Given this list of marker genes ADCY3, RCOR1, SH2D1A, IFRD1, ZFR, SP2, RGS16 (regulator of G protein signaling 16), TRIP10, ID3, SDCBP, ZNF330, SLC16A6, SRSF10, MDFIC, NR5A2, ADGRB2, PRL, ITPKB, FOXJ3 (forkhead box J3), RBBP5, PDCL, RNF103, MAST3, OGDH, SAMM50, PPIF, MBOAT7 (NCBI Gene Id 79143), LSM12, BRD2, SULT1C2, HTR7P1, DENND4B, PUM3, PTPRCAP, PRPF4, KHSRP, CD27, CD6, CD40 (CD40 molecule), HPS5, BAG1, ST3GAL4, SENP6, SOX11, KRIT1, PHF8, TMPO, ARC, TNF, CNR1, TERF2IP, DDX11, TRIM22, DZIP3, TGDS, PFDN1, CXCR2, PBX2, PLK1, CCNE1, CLIP1, REM1, TIPARP, PDE6D, CROT (carnitine O-octanoyltransferase), SLC11A1, YIPF6, CLTB, CLTA, SVEP1, COMT (catechol-O-methyltransferase), UBE2V2, FCN2, STOM, FUT4, HNRNPL, SLCO2B1, SREBF1, NFATC2IP, MDH2, TSC22D2, CD37, APOA4, NPEPPS, CYP2C19, HSD17B3, TRAFD1, PNP (purine nucleoside phosphorylase), CD9, PDCD2, NCKAP1, SAP18, PTS, CST7, HELZ, TRIM21 (NCBI Gene Id 6737), SNX15, PAFAH1B2, ZPR1, PYGM, SBNO2, TLE4, MYRIP, AMIGO2, MGST3, TAF11, COX7A2L, C6orf47, DAXX, PIP5K1A, ARR3, LRRC8B, MARCKS, RAB8A, IQSEC2, UBR4, CD83 (CD83 molecule), COLGALT2, BTBD3, PIGO, SULF1, MX1, CACNG3, SSNA1, AMHR2, RPA1, TOR1B, MUC6, EEIG1, DLEC1, DEDD, CLN5, CIC, DHRS2, PSMB5, COPS7A, ATOX1, AVL9, RFX2, BCAS2, ZNF804A, F3, BCR, ACTN1, HSPA6, NCDN, INPP5B, IGF1, KCNAB1, ITGAL, IFRD2, TNR, RWDD2A, OR7A5, CUL1, NID2, ITIH3, PSMB8, ANGPTL7, RNF14, CNOT4, LMNB2, SACS, FAM168B, SLC25A1, H2BC10, NRTN, FCAR, STAT6, GUSBP11, CCL8, GNA15, CAMK2B, SRPX2, XPO6, GCDH, APLP1, BBS9, PPM1G, CEP250, MRPS12, RBL1, SCN9A, NF2, EWSR1, NUAK1, PCMT1, UGDH, CD72, HIPK1 (homeodomain interacting protein kinase 1), KHK, FUT2, CPNE1 (copine 1), EMP1, PSEN2 (presenilin 2), GDF15, TOP3A, VWF, BRD4, BRD1, here is a description of the gene set: studied in species Homo sapiens Human Gene Set: GSE360_CTRL_VS_B_MALAYI_HIGH_DOSE_MAC_DN from publication Chaussabel D, Semnani RT, McDowell MA, Sacks D, Sher A, Nutman TB (PMID 12663451) Genes down-regulated in comparison of macrophages versus macrophages exposed to B. malayi (50 worms/well). Monocyte-derived dendritic cells (DC) and macrophages (MΦ) generated in vitro from the same individual blood donors were exposed to five different pathogens, and gene expression profiles were assessed by microarray analysis. Responses to Mycobacterium tuberculosis and to phylogenetically distinct protozoan (Leishmania major, L. donovani, Toxoplasma gondii) and helminth (Brugia malayi) parasites were examined, each of which produces chronic infections in humans yet vary considerably in the nature of the immune responses they trigger.